The following is a description of a gene set: A renal system process in which water is taken up from the collecting ducts and proximal and distal loops of the nephron. In non-mammalian species, absorption may occur in related structures. Human Gene Set: GOBP_RENAL_WATER_ABSORPTION species: Homo sapiens, and this is the list of marker genes: AQP3, AQP1, HAS2, HYAL2, MLLT6